The following is a description of a gene set: species: Mus musculus Human Gene Set: MATZUK_SPERMATID_DIFFERENTIATION Reproduction is required for the survival of all mammalian species, and thousands of essential 'sex' genes are conserved through evolution. Basic research helps to define these genes and the mechanisms responsible for the development, function and regulation of the male and female reproductive systems. However, many infertile couples continue to be labeled with the diagnosis of idiopathic infertility or given descriptive diagnoses that do not provide a cause for their defect. For other individuals with a known etiology, effective cures are lacking, although their infertility is often bypassed with assisted reproductive technologies (ART), some accompanied by safety or ethical concerns. Certainly, progress in the field of reproduction has been realized in the twenty-first century with advances in the understanding of the regulation of fertility, with the production of over 400 mutant mouse models with a reproductive phenotype and with the promise of regenerative gonadal stem cells. Indeed, the past six years have witnessed a virtual explosion in the identification of gene mutations or polymorphisms that cause or are linked to human infertility. Translation of these findings to the clinic remains slow, however, as do new methods to diagnose and treat infertile couples. Additionally, new approaches to contraception remain elusive. Nevertheless, the basic and clinical advances in the understanding of the molecular controls of reproduction are impressive and will ultimately improve patient care. Genes important for spermatid differentiation, based on mouse models with male reproductive defects. from publication Matzuk MM, Lamb DJ (PMID 18989307), and this is the list of marker genes: TNP1, PANK2, CIB1, PAFAH1B1, SPMAP2, KRT9, IP6K1, SIX5, CELF1, RNF17, TDRD1, PRM1, CADM1, UBE2B, H1-7, BCL2L2, PARP2, STYX, PPP1CC, PIWIL1, CREM, YBX2 (Y-box binding protein 2), TNP2, MAP7, PRM2, PYGO2, PACRG (parkin coregulated), HIP1, DDX25, CAMK4, SLC12A2 (NCBI Gene Id 6558), FNDC3A, SLC4A2, LMTK2, PRND, TBPL1, ADAMTS2